The following is a description of a gene set: studied in species Homo sapiens Any process that stops, prevents or reduces the frequency, rate or extent of neuron migration. Human Gene Set: GOBP_NEGATIVE_REGULATION_OF_NEURON_MIGRATION, and this is the list of marker genes: GPR173, GNRH1, CX3CL1, NEXMIF, SRGAP2, COL3A1, ADGRG1, ERBB4, NRG3, STAT3, TNN, DRD2